The following is a description of a gene set: Mouse Gene Set: GOBP_MACROPHAGE_COLONY_STIMULATING_FACTOR_PRODUCTION The appearance of macrophage colony-stimulating factor due to biosynthesis or secretion following a cellular stimulus, resulting in an increase in its intracellular or extracellular levels. species: Mus musculus, and this is the list of marker genes: Isl1, Foxp1, Cd34, Tslp, Havcr2